The following is a description of a gene set: from publication Georges SA, Biery MC, Kim SY, Schelter JM, Guo J, Chang AN, Jackson AL, Carleton MO, Linsley PS, Cleary MA, Chau BN (PMID 19074876) Experimentally validated direct targets of MIR192 microRNA; MIR192 caused cell cycle arrest in HCT116 cells (colon cancer). species: Homo sapiens Cell cycle arrest in response to DNA damage is an important antitumorigenic mechanism. MicroRNAs (miRNAs) were recently shown to play key regulatory roles in cell cycle progression. For example, miR-34a is induced in response to p53 activation and mediates G(1) arrest by down-regulating multiple cell cycle-related transcripts. Here we show that genotoxic stress promotes the p53-dependent up-regulation of the homologous miRNAs miR-192 and miR-215. Like miR-34a, activation of miR-192/215 induces cell cycle arrest, suggesting that multiple miRNA families operate in the p53 network. Furthermore, we define a downstream gene expression signature for miR-192/215 expression, which includes a number of transcripts that regulate G(1) and G(2) checkpoints. Of these transcripts, 18 transcripts are direct targets of miR-192/215, and the observed cell cycle arrest likely results from a cooperative effect among the modulations of these genes by the miRNAs. Our results showing a role for miR-192/215 in cell proliferation combined with recent observations that these miRNAs are underexpressed in primary cancers support the idea that miR-192 and miR-215 function as tumor suppressors. Human Gene Set: GEORGES_CELL_CYCLE_MIR192_TARGETS, and this is the list of marker genes: DTL, SMARCB1, PLAU, TENT4A, PPP1CA, KIF14, NCAPH, DLG5, UVRAG, CTCF, KIF20B, RAP1GAP, CRK, BCL2, PLS3, RB1, TUBGCP3 (NCBI Gene Id 10426), RAD21, TOP1, NIN, NBN, SERTAD2, NEK1, MACF1, MTSS1, TDG, HOXA10, NFIB, DBF4B, PRPF38A, CDC14A, MCM3, CDK14, LMNB2, DEK, PAFAH1B1, RAD51, POLQ, CDC73 (NCBI Gene Id 79577), MCM6, TENT4B, CDC7, MCM10, USP1, SH3BP4, EXTL2, KIF23, MIS12, MAD2L1, RAD1, HRH1, MKI67, BRCA1, SEPTIN10, EMP1, ERCC3, CUL5, TDP1, RACGAP1, FGF2, NFYA, PIM1